Given this list of marker genes STN1, H2AC14, POLR2I, POLD4, POLR2F, RFC3, H4C1, WRN, H2AC7, POLR2H, POLR2E, PPP6C, NOP10, DNA2, PRIM2, H2AC20, RUVBL2, CHTF8, H2AC6, CDK2, H2BC12L, POLD1, POLA2, LIG1, DSCC1, POT1, BLM, PPP6R3, H3-3A, RPA2, POLD2, H2BC17, H2BC5, H2BC11, H2AX, H2BC1, RTEL1, TEN1, CCNA1, H2AB1, RFC4, TERF1, H2AJ, WRAP53, TERF2IP, TERF2, H2BC12, FEN1, GAR1, POLR2C, SHQ1, RPA3, POLR2B, PCNA, H2BC4, H2BC3, RUVBL1, TINF2, H2AC4, POLR2D, H2BC21, H2AC18, POLR2J, RFC1, ATRX, H2BC14, POLR2G, H2BC9, ANKRD28, NHP2, H2BC15, RFC5, PIF1, RFC2, POLR2K, ACD, POLA1, H3-4, POLD3, DKC1, H2BC26, CCNA2, CHTF18, RPA1, POLR2L, TERT, DAXX, CTC1, H2AZ2, H2BC13, PRIM1, POLR2A, here is a description of the gene set: part of: Chromosome Maintenance Telomeres are protein-DNA complexes at the ends of linear chromosomes that are important for genome stability. Telomeric DNA in humans, as in many eukaryotic organisms, consists of tandem repeats. The repeats at human telomeres are composed of TTAGGG sequences and stretch for several kilobase pairs. Another feature of telomeric DNA in many eukaryotes is a G-rich 3' single strand overhang, which in humans is estimated to be approximately 50-300 bases long. Telomeric DNA isolated from humans and several other organisms can form a lasso-type structure called a t-loop in which the 3' single-strand end is presumed to invade the double stranded telomeric DNA repeat tract. Telomeric DNA is bound by multiple protein factors that play important roles in regulating telomere length and in protecting the chromosome end from recombination, non-homologous end-joining, DNA damage signaling, and unregulated nucleolytic attack.<br><br>DNA attrition can occur at telomeres, which can impact cell viability. Attrition can occur owing to the "end-replication problem", a consequence of the mechanism of lagging-strand synthesis. Besides incomplete replication, nucleolytic processing also likely contributes to telomere attrition. If telomeres become critically shortened, replicative senescence can result. Thus, in order to undergo multiple divisions, cells need a mechanism to replenish the sequence at their chromosome ends.<br><br>The primary means for maintaining the sequence at chromosome ends in many eukaryotic organisms, including humans, is based on telomerase. Telomerase is a ribonucleoprotein complex minimally composed of a conserved protein subunit containing a reverse transcriptase domain (telomerase reverse transcriptase, TERT) and a template-containing RNA (telomerase RNA component, TERC, TR, TER). Telomerase uses the RNA template to direct addition of multiple tandem repeats to the 3' G-rich single strand overhang. Besides extension by telomerase, maintenance of telomeric DNA involves additional activities, including C-strand synthesis, which fills in the opposing strand, and nucleolytic processing, which likely contributes to the generation of the 3' overhang. Reactome Pathway: Telomere Maintenance species: Homo sapiens